Given this list of marker genes BRAF, NRAS, MMP14, MMP2, TANGO2, DYRK1A, ZEB2 (zinc finger E-box binding homeobox 2), SOX5, MKRN3, ALK, KDM6A, EP300, CYP11B1, KMT2D, RAF1, CREBBP, EIF5A, here is a description of the gene set: Premature thelarche Premature development of the breasts. studied in species Homo sapiens Human Gene Set: HP_PREMATURE_THELARCHE